The following is a description of a gene set: Any process that stops, prevents or reduces the frequency, rate or extent of cellular response to insulin stimulus. Human Gene Set: GOBP_NEGATIVE_REGULATION_OF_CELLULAR_RESPONSE_TO_INSULIN_STIMULUS studied in species Homo sapiens, and this is the list of marker genes: RPS6KB1, TNS2, KANK1 (NCBI Gene Id 23189), GRB14, PTPRJ, MIR107, GRB10, PRKCD, MIR195 (microRNA 195), RBX1 (ring-box 1), PRKCB, NCL, PTPN2, PIP4K2C, NCOA5, MAPKAP1, PRKCQ, PTPN1, CUL7, IRS1, ZNF592, MIR15B, PID1, APPL2, TRIB3, TRIM72, MTOR, PIP4K2A, MIR103A1, GRB7, INPP5K, ENPP1, SLC27A4, PRKAA1, PIP4K2B, GSK3A, LONP1 (NCBI Gene Id 9361), TSC2, IL1B, SOCS3, SOCS1, RPS6KB2, MIR1271, PRKCZ, GPR21, FBXW8, MSTN, AHSG, RELA, BLVRB, NCK1, PTPRE